The following is a description of a gene set: Pathway Definition from KEGG: HH -> PTCH // SMO -> (SMO+EVC) -> (SUFU+KIF7) // GLI => (GLI1,PTCH,HHIP) species: Homo sapiens Human Gene Set: KEGG_MEDICUS_REFERENCE_HEDGEHOG_SIGNALING_PATHWAY Hedgehog signaling pathway. Pathway ID: N00062. Pathway type: Reference. Pathway class: nt06501 HH signaling., and this is the list of marker genes: GLI2, PTCH1, GLI1, HHIP, EVC2, GLI3, DHH, SHH, SUFU, SMO, KIF7, EVC, IHH, PTCH2